Given this list of marker genes ADORA1, CYBA, VAMP8, ATG5, VAMP3 (NCBI Gene Id 9341), P2RY2, AGR2, ADA, HTR4, ALOX12B, SCNN1B (NCBI Gene Id 6338), FOSL2, TRAF3IP2, VAMP2, PRKCE, MUC2, NLRP6, ANO1, here is a description of the gene set: Human Gene Set: GOBP_MUCUS_SECRETION studied in species Homo sapiens The regulated release of mucus by the mucosa. Mucus is a viscous slimy secretion consisting of mucins and various inorganic salts dissolved in water, with suspended epithelial cells and leukocytes. The mucosa, or mucous membrane, is the membrane covered with epithelium that lines the tubular organs of the body. Mucins are carbohydrate-rich glycoproteins that have a lubricating and protective function.